The following is a description of a gene set: Mouse Gene Set: CUI_NEUTROPHIL_IL36A_RESPONSE_DN Genes negatively differentially expressed in cell type: Neutrophil upon treatment with cytokine: IL-36α in mouse lymph nodes in vivo. studied in species Mus musculus from publication Cui A, Huang T, Li S, Ma A, Pérez JL, Sander C, Keskin DB, Wu CJ, Fraenkel E, Hacohen N (PMID 38057668) Cytokines mediate cell-cell communication in the immune system and represent important therapeutic targets. A myriad of studies have highlighted their central role in immune function, yet we lack a global view of the cellular responses of each immune cell type to each cytokine. To address this gap, the authors created the Immune Dictionary, a compendium of single-cell transcriptomic profiles of more than 17 immune cell types in response to each of 86 cytokines (>1,400 cytokine-cell type combinations) in mouse lymph nodes in vivo. A cytokine-centric view of the dictionary revealed that most cytokines induce highly cell-type-specific responses. For example, the inflammatory cytokine interleukin-1β induces distinct gene programmes in almost every cell type. A cell-type-centric view of the dictionary identified more than 66 cytokine-driven cellular polarization states across immune cell types, including previously uncharacterized states such as an interleukin-18-induced polyfunctional natural killer cell state., and this is the list of marker genes: Cd101, Cotl1, Fos, Cst3, Pmaip1, Btg2, Stk17b, Nr4a1, Ncf1, Dusp1, Gm2a, Rgs2, Taldo1, Ptgs2, Rassf3